The following is a description of a gene set: The regulated release of serotonin by a cell. Serotonin (5-hydroxytryptamine, or 5-HT) is a monoamine synthesized in serotonergic neurons in the central nervous system, enterochromaffin cells in the gastrointestinal tract and some immune system cells. Mouse Gene Set: GOBP_SEROTONIN_SECRETION species: Mus musculus, and this is the list of marker genes: Xbp1, Slc18a2, Fcgr3, Fcer1g, Crhr2, P2rx1, Maob, Cd300a, Fcer1a (Fc receptor, IgE, high affinity I, alpha polypeptide), Lgals3, Syk (spleen tyrosine kinase), Htr7, Slc6a4, Crh, Htr1a, Htr1b, Cnr1, Hrh3